The following is a description of a gene set: Human Gene Set: GENTILE_UV_HIGH_DOSE_DN studied in species Homo sapiens from publication Gentile M, Latonen L, Laiho M (PMID 12907719) DNA damage caused by UV radiation initiates cellular recovery mechanisms, which involve activation of DNA damage response pathways, cell cycle arrest and apoptosis. To assess cellular transcriptional responses to UVC-induced DNA damage we compared time course responses of human skin fibroblasts to low and high doses of UVC radiation known to induce a transient cellular replicative arrest or apoptosis, respectively. UVC radiation elicited >3-fold changes in 460 out of 12,000 transcripts and 89% of these represented downregulated transcripts. Only 5% of the regulated genes were common to both low and high doses of radiation. Cells inflicted with a low dose of UVC exhibited transcription profiles demonstrating transient regulation followed by recovery, whereas the responses were persistent after the high dose. A detailed clustering analysis and functional classification of the targets implied regulation of biologically divergent responses and suggested involvement of transcriptional and translational machinery, inflammatory, anti-proliferative and anti-angiogenic responses. The data support the notion that UVC radiation induces prominent, dose-dependent downregulation of transcription. However, the data strongly suggest that transcriptional repression is also target gene selective. Furthermore, the results demonstrate that dose-dependent induction of cell cycle arrest and apoptosis by UVC radiation are transcriptionally highly distinct responses. Selected genes down-regulated in WS1 (fibroblast) in response to irradiation with high dose UV-C., and this is the list of marker genes: DICER1, SEC24B, MFAP1, TLK2, STRN3, COIL, LSM2, GINS1, ELOB, TNFAIP8, EPS8, NUP153, MAML1, ASPH, EIF4E, BRD8, KANK1, TBL1X, BMPR1A, FILIP1L, PHF3, KIF2A, RAB14, PUM1, EFCAB14, GTF2E1, RND3, MAP1B, DDX3X, MCL1, TLE1, ZMYND8, PITPNB, ELF4, DKK1, TLK1, UVRAG, PMAIP1, MACIR, DUSP11, CUL1, PODXL, KRIT1, BMI1, RBMS1, ZFP36, PCGF3, CASP3 (caspase 3), GAS1, ATF3, PDGFRA, NRIP1, HMGA2, PRKCD, PMP22, PUM2, COX6A1, BDNF, RNF4, MEIS2, BACH1, STX7, IFNGR2, UGCG, PTK2, RRAS2, CHD1, FGF5, DUSP7, RARS1, SRF, ZNF623, ZFP36L2, HOXB2, ID2, JMJD6, MBD2, TARDBP, LSM14A, TIPARP, ZBTB18, DDIT4, DDX17 (DEAD-box helicase 17), AURKA, MPHOSPH6, DR1, CDK7, CTDSP2, THBS1, C2CD2, LRBA, FOXD1, AMD1, SLBP, LBR, ATP2A2, RPP40, QKI, SIAH1, KPNA2, AHDC1, RYBP, ZNF117 (NCBI Gene Id 7670), RAPGEF2, PDCD10, SECISBP2L, SIAH2, IGF2BP3, RIPK1, NFYA, SNRNP35, PNN (pinin, desmosome associated protein), HAS2, PIKFYVE, STAM, CEBPD, POLE2, N4BP1, CCNB1, IL4R, PPP2R1B, NAV3, SMURF2, NFE2L2, PXDC1, NUPR1, H2BC6, TM4SF1, KLF10, IL11, NR2F6, PUDP, CENPA, PHC2, ZMIZ1, BCAR3, XPO1, SMAD3, STX3, CHTOP, TAF11, CHSY1, RUNX1, PTPN1, CDC6, PLA2G6, SFI1, FOSL2, VEGFC, UAP1, HMGB2, SAMD4A, EAPP, SMAD7, MAT2A, H2AC18, SCHIP1, CDK8, USP10, TSC22D3, RBM5, CLINT1, GNE, RAD21, MMP3, ZHX3, TUBGCP3, GATA2, WEE1, GADD45A, MET, TLE4, NFYB (NCBI Gene Id 4801), UBTF, ISG15, PNO1, RAB1A, DUSP5, PAFAH1B1, POGZ, TNFAIP3, TRIP10, GNAI1, FERMT2, ZNF146, SPEN, ZBED4, LHFPL2, SLC20A2, DUSP1, SLC25A44, SRSF3, ZFAND5, EDRF1, PRSS3, CKS2, THUMPD1, HMGXB4, RPL34P1, TOPBP1, NASP, DYRK1A, MRFAP1L1, UBE2G1, E2F3, PRRX1, ATP13A3, CCN1, MTMR3, PGRMC2, NFIL3, RAB11A, TRIB2, JUND, EMG1, POM121 (POM121 transmembrane nucleoporin), BHLHE40, ITGA6, HTR6, E2F2, RABGAP1, MLX, CDR2, MORC3, SAT1, LPAR1, WBP1L (WW domain binding protein 1 like), NCK1, FADD, FOXJ3, TNFRSF1A, HERPUD1, ZC3H4, CNOT2, USP32P2, BLCAP, NTF3, RRAD, TRIM13, NDUFV2, KIF23, ZNF217, STXBP3, FSTL3, SNX4, FZD2, SS18, FZD7, COL13A1, ARL4C, ARID5B, UFL1, HBEGF, ADNP, CRKL, BNIP2, CASP8, EEF1E1, GEM, SSH1 (slingshot protein phosphatase 1), CCN2, SERTAD2, NOP16, MAPK6, PHTF2, PKP4, SATB2, ATP6V1B2, USP1, H2BC10, CXCL12, RHOB, PLK4, NCOA3, GREM1, UBE2N, FBXO46, ARF6, UNG, SNRNP40, PPP2R5C, AUTS2, TRAPPC8, PLPP3 (NCBI Gene Id 8613), ID1, NIPSNAP2, TPST1, CSTF3, DLX2